Given this list of marker genes Cdk2ap1rt, Mta2, Cdk2ap2, Mbd3, Chd3, Sall1, Mbd2, Mta3, Rbbp4, Cdk2ap1, Gatad2a, Hdac1, Chd5, Hdac2, Chd4 (chromodomain helicase DNA binding protein 4), Rbbp7, Gatad2b, Mta1, here is a description of the gene set: studied in species Mus musculus An approximately 2 MDa multi-subunit complex that exhibits ATP-dependent chromatin remodeling activity in addition to histone deacetylase (HDAC) activity, and has been shown to establish transcriptional repression of a number of target genes in vertebrates, invertebrates and fungi. Amongst its subunits, the NuRD complex contains histone deacetylases, histone binding proteins and Mi-2-like proteins. Mouse Gene Set: GOCC_NURD_COMPLEX